The following is a description of a gene set: Any process that stops, prevents, or reduces the frequency, rate or extent of macrophage apoptotic process. studied in species Homo sapiens Human Gene Set: GOBP_NEGATIVE_REGULATION_OF_MACROPHAGE_APOPTOTIC_PROCESS, and this is the list of marker genes: CCR5, GHSR, NOD2, CCL5, MIRLET7B, SELENOS, IRF7